The following is a description of a gene set: species: Homo sapiens Human Gene Set: GSE3982_CENT_MEMORY_CD4_TCELL_VS_NKCELL_UP Genes up-regulated in comparison of central memory CD4 T cells versus NK cells. In the present study we used Affymetrix oligonucleotide microarrays to produce gene transcription profiles for the major leukocyte types in humans. This comprehensive dataset enabled us to not only establish which genes were expressed in each leukocyte type, but also which genes were expressed in each subset after activation. The used of a comprehensive dataset of gene profiles from all the major human leukocyte subsets enabled a novel and powerful means for identification of genes associated with single leukocyte subsets, or different immune paradigms. from publication Jeffrey KL, Brummer T, Rolph MS, Liu SM, Callejas NA, Grumont RJ, Gillieron C, Mackay F, Grey S, Camps M, Rommel C, Gerondakis SD, Mackay CR (PMID 16474395), and this is the list of marker genes: E2F3, CDKAL1, ZSCAN18, IGFBP2, TUFT1, EVC, SLAMF1, HBQ1, DNAH7, ZC3HAV1, HRH3, CAMTA1, ZNF862, EPHA1, AQP3, CRACDL, OR1A1, HABP4, ICOS, ANKRD2, PCID2, CNTNAP1, LRRN3, RPL6, RPL5, GPR183, CENPF, CISH, TAX1BP1, PUS1, SEM1, SLC19A1, NIT2, PCNX2, SLC44A1, ADNP2, BBS9, CDH8, UBASH3A, ENGASE, AHR, RHOH, DGKA, RPL27, SLC22A1, RAB40A, HLF, UBE2G2, PCYOX1L, IMPACT, GLRA2, CAND2, PDE4B, FAN1, UGT8, KLHL3, INPP4B, MID2, PCDHA10, NEFL, ANKRD55, CATSPERB, EEIG1, PHF10, H3-4, PLCB4, SGSM2, BHMT2, HNRNPA1, HNRNPU, CRISP2, DCP1A, TBX4, AHNAK, DPH2, EDEM1, FAM174B, EEF1B2, PLEKHA5, TRIM46, ACP6, LRRC32, CCL24, KYAT3, GABBR1, SSPN (sarcospan), CD28, CDR2L, RPL32, LGALS3BP, SYMPK, CHMP7 (NCBI Gene Id 91782), SIRPG, TAB2, ASXL1, DUSP8, WRAP73, SLCO1B1, PLSCR3, MALT1, CCDC82, THPO, TAS2R10, PFN2, RAPGEF6, LARP1, CNOT1 (CCR4-NOT transcription complex subunit 1), EPM2A, RPL4, H4C1, TRADD, RPL10A, POLI, RGCC, SSR3, TUBD1, PPA1, MIR124-1HG, H4C9, URI1, WNT7A, ACOXL, TMEM63A, SEPTIN7P11, EIF2B5, MYO5C, FBXO22, CACNA1I, NET1 (neuroepithelial cell transforming 1), IRAK4, LRRC14, KIF18A, KCNV1, RPL12, ENOSF1, RAD54B, ITGA3, CBR3, HSPB2, PLA2G6, PRKG1, DIP2C, H2AC17, DDX18, ICA1, PLEC, ZNF281, ZNF442, KDM6B, KCNK7, MCL1, LDHB, POLR3G (NCBI Gene Id 10622), SLC18A2, ACHE, NPR2, ADPRM, RPS28, TRBC1, CSF1, UBB, PRR14, ZCWPW1, NOSIP, ARHGAP45, USP13, KIF5C, RPL30, USP36, RLN2, DNAI7, RPL24, HTR5A, PNPLA3, ESD, WDR76, FOSL1, CDC14B, CD40LG, RPL7A, SGCB (NCBI Gene Id 6443), LRRC20, CASP1, AMPD3, STN1, PHACTR2, TGIF2, VPREB1, HMX1, CD2, RBP3, TSBP1, PITPNA, WDR91, HRC, ZBTB44, RALA, POLR1C